Given this list of marker genes SLC52A3, COQ4, GBA2, SPART, NFU1, KIF5A, SPG11, RTN2, MTRFR, here is a description of the gene set: Knee clonus Human Gene Set: HP_KNEE_CLONUS species: Homo sapiens Clonus is an involuntary tendon reflex that causes repeated flexion and extension of the foot. Knee clonus can be tested by rapidly pushing the patella towards the toes.